The following is a description of a gene set: Human Gene Set: GSE14000_4H_VS_16H_LPS_DC_UP Dendritic cells (DCs) are the sentinels of the mammalian immune system and they undergo a complex maturation process mediated by activation upon pathogen detection. Recent studies described the analysis of activated DCs by transcriptional profiling, but translation regulation was never taken in account. Therefore, the nature of the mRNAs being translated at various stages of DC activation was determined with the help of translational profiling, which is the sucrose gradient fractionation of polysomal-bound mRNAs combined to microarrays analysis. Total and polysomal-bound mRNA populations were compared in immature (0h) and LPS-stimulated (4h and 16h) human monocyte-derived DCs with the help of Affymetrix microarrays. Biostatistical analysis indicated that 296 mRNA molecules are translationally regulated during DC-activation. The most abundant biological process among the regulated mRNAs was protein biosynthesis, indicating the existence of a negative feedback loop regulating translation. Interestingly, a cluster of 17 ribosomal proteins were part of the regulated mRNAs, indicating that translation may be fine-tuned by particular components of the translational machinery. Our observations highlight the importance of translation regulation during the immune response, and may favour the identification of novel gene clusters or protein networks relevant for immunity. Our study also provides information on the possible absence of correlation between gene expression and real protein production in DCs. Genes up-regulated in comparison of dendritic cells (DC) at 4 h after LPS (TLR4 agonist) stimulation versus those at 16 h after the stimulation. species: Homo sapiens from publication Ceppi M, Clavarino G, Gatti E, Schmidt EK, de Gassart A, Blankenship D, Ogola G, Banchereau J, Chaussabel D, Pierre P (PMID 19943945), and this is the list of marker genes: IQSEC1, APOM, PTPRH, EFCAB14, SRXN1, SV2B, RLIM, PDK3, ZNF426, MORN2, COP1, NCOA7 (nuclear receptor coactivator 7), LRMDA, CLTC, PCGF3 (polycomb group ring finger 3), TPT1P8, NDUFB6, ATF6B, CD99P1, DCLRE1C, NRP1, DTX4, CLCN5, CD33, FAM168B, EPOP, RUNX1, SKAP2, BLVRB, RAB7B, PARP14, ASRGL1, RTN3, RPL23A, AMPD2, MEGF9, ACTN1, SYNGR4, SLC25A5, IL1RAP, ATP13A3 (NCBI Gene Id 79572), CUTA, TECR, CALML4, CLDN4, DAP, MGST2, METTL22, CBL, DNPH1, EVL, KRT17, TNC, CLCNKB, PON2, S100A4, PARP4, ATP5PD, RPS3A, VPS37B, DIP2B, SDHC, NIPA2 (NCBI Gene Id 96367), RPS11, PANK3, LIMS1, GPM6A, GPBAR1, ANXA10 (annexin A10), KLK14, LMAN1, PKD1, ABHD14B, SCGB1A1, UQCC5, EPAS1 (endothelial PAS domain protein 1), CYFIP1, NDUFB1, SPCS3, MPP1, AHCY, MKKS, BTG2 (BTG anti-proliferation factor 2), MAP1S, ATXN1, SNX29, OASL, TMEM154, DGAT1, NDUFV1, IL1R2, RPL22, ATM, ATP6AP2, ABL2, QPRT, FNDC8, MAP4K1, RIGI, PON1, SLC2A3, VPS9D1, MACROH2A1, GALR3, RPS13, GLIPR1, TBC1D5, REV3L, SRPK2, UBASH3B, FAM120A, MKNK1, AP1S2, ZC3HAV1, EIF3K, ASPHD2, EMB, AAK1, TMED10, ATP5MC1, PRKX, RIN3, CSK, LTB4R, TSPAN32, PLEKHB2, TMX2, GGCT, RNF130, RXRA, ZC3H12C, RAB5A, F13A1, LRRC4, TMEM33, LTA4H, SEPTIN9, RARG, MIR924HG, NDUFA4, CIITA, RRM2B, TPMT, KLF9, ESYT1, RPS12, WDFY3, OSGIN1, PEPD, CENPW, IL17RA, P2RY6, GRP, GARNL3, PARVG, NCR3, GASK1B, AP1B1, ATP5PF, NEMP1, HOMER1, PLA2G4A, GARS1, SLC27A1, SYNE3, MPC1 (mitochondrial pyruvate carrier 1), ATP1B1, DNASE1L3, UQCRH, GAPVD1, CARD19, SLC46A3, VAMP8, UGGT1, COMMD6, FLT1, ATP5PB, DGKH (NCBI Gene Id 8524), GALM, CRYL1, GALNT1, HTT, GSTT1, PTPN11, FCER2, TNF, ACTR2, RIDA, MSRA, PIP5K1C, RPL30 (NCBI Gene Id 6156), LSMEM2, CDC42EP5, NDUFB2, SCP2, SAMHD1, MBNL1